Given this list of marker genes FOXC1, HAND2, CCN1, NKX2-5, FOXC2, TGFB2, BMP4, here is a description of the gene set: Human Gene Set: GOBP_APOPTOTIC_PROCESS_INVOLVED_IN_HEART_MORPHOGENESIS species: Homo sapiens Any apoptotic process that contributes to the shaping of the heart.